Given this list of marker genes EIF4G1, NCK1, DNAJC3, DDX3X, NCK2, here is a description of the gene set: Human Gene Set: GOBP_POSITIVE_REGULATION_OF_TRANSLATION_IN_RESPONSE_TO_ENDOPLASMIC_RETICULUM_STRESS species: Homo sapiens Any process that activates, or increases the frequency, rate or extent of translation as a result of endoplasmic reticulum stress.